The following is a description of a gene set: studied in species Homo sapiens Human Gene Set: GSE25088_IL4_VS_IL4_AND_ROSIGLITAZONE_STIM_STAT6_KO_MACROPHAGE_DAY10_UP Genes up-regulated in bone marrow-derived macrophages with STAT6 knockout treated with IL4: control versus rosiglitazone. from publication Szanto A, Balint BL, Nagy ZS, Barta E, Dezso B, Pap A, Szeles L, Poliska S, Oros M, Evans RM, Barak Y, Schwabe J, Nagy L (PMID 21093321) C57Bl/6 wild-type and STAT6 KO mice were used to study PPARg and IL-4 signaling. Bone marrow of 3 mice per group was isolated and differentiated to macrophages with M-CSF (20 ng/ml). 20 ng/ml IL-4 was used to induce alternative macrophage activation and 1 uM Rosiglitazone (RSG) was used to activate PPARg. From each mouse 4 samples were generated: 1. M-CSF, 2. M-CSF+RSG, 3. IL-4 and 4. IL-4+RSG. All compounds were added throughout the whole differentiation process, and frech media was added every other day. Control cells were treated with vehicle (DMSO:ethanol). After 10 days, RNA was isolated and gene expression profiles were analyzed using Mouse Genome 430 2.0 microarrays from Affymetrix., and this is the list of marker genes: ITPK1, SLF1, ZNF516, APLP2, MAP2K6, PCMTD1, RAB11FIP4, ATG9A, MYCBP, SMURF2, BICD2, MOB3A, PGGHG, SPTSSA, ABHD2, CCNY (cyclin Y), MED13L, CPVL, CRISPLD2, CYP4F3 (NCBI Gene Id 89256), RSBN1L, CLEC4C, PHKA2, LILRA1, HIPK3, TLR5, DEF8, TMEM164, LTA4H, NDUFB3, BCAP31, TRERF1, AKNA, HAL, LST1, ARHGAP30 (Rho GTPase activating protein 30), HHEX, HYCC2, PDZD8, SLC37A3, GNAI2, GIMAP4, MAP3K2, MEGF9, PAIP2, CALCOCO1, ADD3, ZNG1A, WDR26, WIPI2, MPZL3, ZNF33A, CELF2, RAB11FIP1, FAM174A, MAP3K5, C11orf21, MTURN, NTN4, NAAA, MANSC1, DPP8, UBXN6, NPEPPSP1, TRIM27, TUBA1C, RCN3, CABIN1, PADI4, LTB, MGAM, RAB3D, MBTD1, LAMTOR5, EIF4EBP2 (eukaryotic translation initiation factor 4E binding protein 2), TRIM25, ELAPOR1, C11orf68, COTL1, ACTG1, LRRFIP1, CEACAM4, WDFY2, NCF1C, TTLL3, DOCK5, NCOA2, ULK1, SSH2, ATP5IF1, KPNB1, RUNX2, SLC35E2B, ZNF185 (zinc finger protein 185 with LIM domain), RMI1 (NCBI Gene Id 80010), NLRP12, PRCP, HCLS1, ZDHHC18, TMX4, ARRB2, KLHL2, C8orf88, AGTPBP1, GLT1D1, CDA, SULT1B1, EIF4E3, ADGRE3 (NCBI Gene Id 84658), PADI2, PHF21A, RERE, KDM7A, SLC25A37, TNRC6B, STK4, ARHGAP9, TBC1D1, NUP50, MSRB1, CTSC, MYH11, TMEM65, LIMD2, KLF3, H2AZ1, PRDX3, CAPZB, AKT1, CD52, PACS1, MBOAT1, SLC15A4, STX16, KIAA0040, FCGR3B, CDIPT, ACAP1, PPP4R1, DHRS9, PHF3, PTEN, EXOC6, FKBP8 (FKBP prolyl isomerase 8), PHF2, ATP2B4, RGL4, DHTKD1, MPP7, OSTF1 (NCBI Gene Id 26578), TLR6, LCLAT1, PROK2, DEF6, MSH6, DSTYK, ZBTB44, NFATC3, MBOAT2, CXorf38, XKR8, ARHGAP25, TGFA, KBTBD7, MS4A6A, TAS2R40, MAN1A1, PGAM1, CKLF (chemokine like factor), LIN7A, TOB2, NEDD8, MYO1F, CCDC28A, ENSG00000284948, TMEM50A, CAMP, DGAT1, NUDT5, H2AC14, ARHGAP19, GNAQ, IRAG2, LBR, XRCC4, RALBP1, F2RL1, NDE1, NIN, GALNT3, ATG16L2, MTMR3, BAZ2B, SLC45A4, FHIP2A, S100A12, TSPO, NHSL2